Given this list of marker genes CCR6, IL12B, MLX, TBX1, CAV1, HLA-B, MYMK, RREB1, ARVCF, HLA-DRB1, MYMX, COMT, RET, HIRA, GP1BB, UFD1, JMJD1C, SEC24C, TLR7, CCN2, IRF5, here is a description of the gene set: Hypertensive crisis species: Homo sapiens Human Gene Set: HP_HYPERTENSIVE_CRISIS